The following is a description of a gene set: studied in species Homo sapiens Human Gene Set: SREBP1_Q6 Genes having at least one occurrence of the motif CACSCCA in the regions spanning 4 kb centered on their transcription starting sites. This matches the SREBF1 transcription factor binding site V$SREBP1_Q6 (v7.4 TRANSFAC)., and this is the list of marker genes: KPNB1, HNF1A, PTK2B, SIK2, KIF1B, DDR1, PDXP, DHX58, ANP32A, GRIA1, TYRO3, PDP2, DDX17, RBX1, HOXC11, NUFIP2, EPO, GREM1, PEX16, ERF, CLDN5, LRCH4, C3orf62 (NCBI Gene Id 375341), LBX1 (ladybird homeobox 1), SLCO3A1, DCTN1, NBEA, SLC39A14, MAML3, ZNF532, ABCG4, MAP1A, ZFYVE1, HIF1A, DLK1, SIPA1L2, CACNA1D, SMTN, ESR1, PRRT2, FLNC (NCBI Gene Id 2318), SRRM4, NFIX, HOXB2, SLC2A4, NF1, EVX1, KLF12, PPP1R10 (protein phosphatase 1 regulatory subunit 10), SERPINI1, CACNB1, ADGRL1, CLSTN3, ATXN7L1, SREBF2, EN1, DLG2, EMP1, RCOR2, FXYD1, JADE2, ETV5, SYNPO2L, RPRD1A, JUP, CDC42EP4, REL, STAT6, KMT2E, FOXP4, MT4, B4GALT2, PLA2G3, MEOX2, SLC4A1, LDLR, GRID2, DTX1, MAPKAPK3, CORO1A, MRPS18B, FCHSD2, KRT17, PCF11 (NCBI Gene Id 51585), LEFTY1, POU4F2, RNF112, DPYSL2, NFAT5, SLC4A10, PHLDB3, KLK13, AGER, SHKBP1, CCDC140, TAOK1, ZFP36L1, DDX6, PDCD10, SYTL2, HSPA9, ATE1, CASZ1, GFAP, GNAO1, STX4, HNF1B, SOX12, GNAS, ENO2, ERC1, FBXO24, RHOA, GARIN4 (golgi associated RAB2 interactor family member 4), MEX3B, RHOG, NMT1, CLASP1, EFCAB2, ACTC1, MSI1, MMP14, RBP5, NDUFAF3, SPI1, KCNK10, GRWD1, RHEBL1, SPEM1, KCNN3, PDE5A, KCNMB1, MACF1 (NCBI Gene Id 649183), HOXA3, HOXC4, GAP43, ITPR3, TRERF1, ADGRL3, SRCIN1, PSD, DYRK1A, TFAP2B, FBRS, RAB30, PLCB3, ZIC4, ZNF593, ANXA9, CAVIN1, CDK2AP1, UBQLNL, ARHGAP30, MYL6, TEAD2, HYAL1, IRF2BPL, YWHAQ, LIN28A, NSF, DALRD3, GPR85, ZBTB18, MYH10, RPS10, TNS1 (tensin 1), ATP6V1A, AAMDC, RAB10, ATP6V0C, ZNF296, LRP8, PDGFB, SLC25A37, NTRK3, SSBP2, GUCA2B, PAX3, PIAS1, SIX4, PRKD2, LASP1, TIMM10B, SLIT3, NECAP1, IMMT, ARHGDIB, ZBTB7B, DHH, KCNK7, LMX1A, FADS3 (fatty acid desaturase 3), HOXA11, DCAKD (dephospho-CoA kinase domain containing), NDRG2, TMEM119, NECTIN1, SLC24A1, TRAF4, SALL1, INPP4A, NOL4L, MTMR3, ARFIP2, INTS9, CRLF1, CLIC1, FABP6, HSPG2, DUSP8, SORBS1, DSG4, NRGN, NEUROD2, NR1D1, DLGAP4, RSF1, LINC03040, IGF2BP1, STX1A, NFATC4, TGFB1I1, AP1G2, EMX2, BCL6B, GNL3LP1, NAA50, ZBTB9, CEBPB, ATXN7L2, TIMP4, LRRN1, MYL11, RBFOX1, PACSIN3, CNIH2, BAZ2A, EIF4G2, RARG, KMT2A, PKP3, TBCC, IMPDH2, HOXD10, ARMC12, DNMT3B, MACROH2A1 (macroH2A.1 histone)